The following is a description of a gene set: Translation that occurs at the synapse. Mouse Gene Set: GOBP_TRANSLATION_AT_SYNAPSE studied in species Mus musculus, and this is the list of marker genes: Rps11, Rpl36a, Rpl26, Rpl17, Rps28, Rps27, Rpl9, Rps27a, Rplp2, Rpl7, Rpl5, Rpl34, Rpl23a, Rps14, Rpl29, Rps26, Rps5, Rpl32, Rpl10, Rpl37, Rps12, Rpl35a (NCBI Gene Id 68254), Rpl8, Rpl7a, Rpl27a, Rpl27, Rpl14, Rpl23, Rpl15, Eef2, Rpl28, Rpl38, Rpl24, Rpl22, Rpl12, Rpl36, Rpl13a, Rpl6 (ribosomal protein L6), Rps24, Rps10, Rpl13, Rpl37a, Uba52, Rpl4, Rpl35, Rps15a, Rps16, Rpl10a